Given this list of marker genes SEC24B, GRXCR2, LHFPL5, PLS1, NHERF1, TPRN, GRXCR1, WHRN, CLRN1, CDH23, STRC, TRIOBP, SCRIB, CLRN2, TECTA, ANKRD24, SOD1, PDZD7, REST, MYO7A, here is a description of the gene set: Human Gene Set: GOBP_AUDITORY_RECEPTOR_CELL_STEREOCILIUM_ORGANIZATION A process that is carried out at the cellular level which results in the assembly, arrangement of constituent parts, or disassembly of a stereocilium. A stereocilium is an actin-based protrusion from the apical surface of auditory hair cells. species: Homo sapiens